Given this list of marker genes ARHGAP18, PALM2AKAP2, COX7A1, H2AJ, EPB41L4A-AS1, SOX4, FXYD1, PLAC9, HSPG2 (NCBI Gene Id 7796), ERG, JAG1, RASL12, CD59, HES4, ANGPT2, BCAM, RRAS, SEPTIN4, ADGRF5, TSHZ2, DDR2, TM4SF1, SOD3, TCEAL1, TINAGL1, TNS1, ARL4A, TCEAL4, PKIG (cAMP-dependent protein kinase inhibitor gamma), CD9, PALLD, LDB2, GJC1, KRT19, CRIM1, CAV1, TIE1, SELENOW, GSTM3, RHOBTB3, TIMP3, FBLN1, CAV2, SCD5, PDLIM1, MYL6, S100A11, here is a description of the gene set: studied in species Homo sapiens Human Gene Set: JONES_OVARY_MAST_CELL from publication Jones ASK, Hannum DF, Machlin JH, Tan A, Ma Q, Ulrich ND, Shen YC, Ciarelli M, Padmanabhan V, Marsh EE, Hammoud S, Li JZ, Shikanov A (PMID 38578993) Marker genes selected by filtering the centroid data for genes with a value > 0 for the given cell type The reproductive and endocrine functions of the ovary involve spatially defined interactions among specialized cell populations. Despite the ovary's importance in fertility and endocrine health, functional attributes of ovarian cells are largely uncharacterized. Here, we profiled >genes in 257 regions from the ovaries of two premenopausal donors to examine the functional units in the ovary. We also generated single-cell RNA sequencing data for 21,198 cells from three additional donors and identified four major cell types and four immune cell subtypes. Custom selection of sampling areas revealed distinct gene activities for oocytes, theca, and granulosa cells. These data contributed panels of oocyte-, theca-, and granulosa-specific genes, thus expanding the knowledge of molecular programs driving follicle development. Serial samples around oocytes and across the cortex and medulla uncovered previously unappreciated variation of hormone and extracellular matrix remodeling activities. This combined spatial and single-cell atlas serves as a resource for future studies of rare cells and pathological states in the ovary.